The following is a description of a gene set: studied in species Homo sapiens from publication Bhattacharyya S, Deb J, Patra AK, Thuy Pham DA, Chen W, Vaeth M, Berberich-Siebelt F, Klein-Hessling S, Lamperti ED, Reifenberg K, Jellusova J, Schweizer A, Nitschke L, Leich E, Rosenwald A, Brunner C, Engelmann S, Bommhardt U, Avots A, Müller MR, Kondo E, Serfling E (PMID 21464221) Human Gene Set: GSE21063_3H_VS_16H_ANTI_IGM_STIM_NFATC1_KOBCELL_UP Genes up-regulated in B lymphocytes with NFATC1 knockout stimulated by anti-IgM: 3h versus 16h. Triggering of B cell receptors (BCR) induces a massive synthesis of NFATc1 in splenic B cells. By inactivating the Nfatc1 gene and re-expressing NFATc1 we show that NFATc1 levels are critical for the survival of splenic B cells upon BCR stimulation. NFATc1 ablation led to decreased BCR-induced Ca++ flux and proliferation of splenic B cells, increased apoptosis and suppressed germinal centre formation and immunoglobulin class switch by T cell-independent antigens. By controlling IL-10 synthesis in B cells, NFATc1 supported the proliferation and IL-2 synthesis of T cells in vitro and appeared to contribute to the mild clinical course of Experimental Autoimmune Encephalomyelitis in mice bearing NFATc1-/- B cells. These data indicate NFATc1 as a key factor controlling B cell function., and this is the list of marker genes: SYT8, CYP51A1, DCDC2, FCRL1, ARRB2, SLC12A2, DDX20, PID1, TMEM267, RNF180, FKBP11, ZNF449, GTSF1, NECTIN1, PDE2A, PLXNC1, TTLL4, CLN8, DAG1, ATP2A2, FXYD6, ELF3, ATL1, SLC22A9, FGFR1, ZBTB26, HIRIP3, TLR5, BCL6, THBS1, CNR1, ZNF629, GRM5, HOMER2, TAFA4, C4orf19, CD53, TXNDC5, PDAP1, RAB29, TTC16, PER3, TMEM59L, FAM168B, STARD6, IGFLR1, CD93, MPDZ, UBR3, CAPN2, CDC20, C3orf70, SLC25A31, GNAZ, LXN, SYNE4, RELL1, MYBL1, UBE2E3, TNFRSF17, APOC2, TLCD1, HHIPL2, THBD, SLC44A1, D2HGDH, VTN, NCAM1, CD300LB, TSLP (thymic stromal lymphopoietin), THAP2, AGO4, GAS2L1, SERBP1, PLEKHG5, AHNAK, CMSS1, CDR2, NUCKS1, TCF4, DDAH2, POU2AF1, HFE, KCNK6, FBXO32, HELB, ASNS, MEF2C, NIBAN2, MYC, POR, B4GALT6, ANGPTL7, RASA3, FN1, SRMS, ST6GAL1, NARS1, MRPL33, NR2E3, PTPRS, BNIP3L, HSP90AA1, EGLN3, CDT1, SOD1, ITGB5 (integrin subunit beta 5), OSBPL8, FGD4, SQLE, FBXO2, RPRD1A, BMI1, KCTD2, SRCAP, MOGAT1, P3H2, DNASE2, SLC40A1, BAIAP2L1, IARS1, ZNF511, SPART, WDR12, URB1, NAV1, APOLD1, LYL1, NREP, AP1S2, EPPK1, CYP3A4, SSR1 (signal sequence receptor subunit 1), SF1, BCAT1, CKAP4, RUFY1, HEXB, ITGAV, ARL6IP4, RASL10A, DTX4, ARHGAP22, PRRG1 (NCBI Gene Id 5638), DTX2, MYOG, CDH23, CAP2, BMPR2, CNTN3, COLEC12, GRB7, CPNE8, ELOVL6, FBXO15, CLMP, FAM20C, TMC6, MGAT5, PLCB3, TSGA13, GCAT, ERI2, PFKFB4, FABP4, GDA, GLUL, TUG1, ZNF384, RASAL2, TUT4, CSAD, MDM1 (Mdm1 nuclear protein), ATG13, H1-0, COPG2IT1, BLNK, MORF4L2, MATN2, COX7B2, NES, PPARG, SPIC, FEM1C, CNPY2, FOXO3, GPR183, BEX3, PKP2, MDC1, SAMD11, RAD50, OTULINL, ADAM2, GAS2L3, GDF2, PDXK, ADAM10, LRRC8A